The following is a description of a gene set: studied in species Mus musculus Any process that activates or increases the frequency, rate or extent of the assembly of pseudopodia. Mouse Gene Set: GOBP_POSITIVE_REGULATION_OF_PSEUDOPODIUM_ASSEMBLY, and this is the list of marker genes: Cdc42ep3, Ccl21b, Ccl21a, Gm14137, Cdc42ep1, Ccl21e, F2rl1, Kit, Cdc42ep5, Cdc42ep2, Cdc42ep4, Cdc42, Ccl21d, Ccl21f, Apc (APC, WNT signaling pathway regulator)